Given this list of marker genes ZFAND2A, FZR1, RNF180, RFPL1, PAQR3, STUB1, SOCS5, CEBPA, KLHL40, SMAD7, DNAJB2, PSMD10, SH3RF2, SH3RF1, MAPK9, TF, AXIN2, AURKA, AXIN1, PLK3 (polo like kinase 3), GSK3A, DDA1, DET1, CBFA2T3, CDC20B, MDM2, ELOB, BAG2 (BAG cochaperone 2), NOP53, PLK1, TRIB3, BBS7, RAD23A, CSNK1A1, CDC20, SIRT6, GSK3B, RCHY1, ZYG11B, ZER1, PRKN, DDRGK1, HECTD1, PIAS1, CHFR, SIRT2, GCLC, TRIB1, SUMO1, TRIB2, HSPA1B, SH3RF3, COP1, RACK1, DVL1, GABARAP, GBA1, USP5, FBXO22, FBXW8, HSPA1A, PABIR1, PSEN1, CSNK1E, HSPBP1, PRICKLE1, SIRT1, VCP, CSNK1D, DAB2, LRRK2, NKD2, SOCS4, TAF1, RBX1, AKT1, CLU, NUB1, HAMP, SUMO2, KEAP1, IL33, here is a description of the gene set: Human Gene Set: GOBP_POSITIVE_REGULATION_OF_PROTEASOMAL_UBIQUITIN_DEPENDENT_PROTEIN_CATABOLIC_PROCESS studied in species Homo sapiens Any process that activates or increases the frequency, rate or extent of the breakdown of a protein or peptide by hydrolysis of its peptide bonds, initiated by the covalent attachment of ubiquitin, and mediated by the proteasome.